The following is a description of a gene set: species: Mus musculus from publication Brown AL, Wilkinson CR, Waterman SR, Kok CH, Salerno DG, Diakiw SM, Reynolds B, Scott HS, Tsykin A, Glonek GF, Goodall GJ, Solomon PJ, Gonda TJ, D'Andrea RJ (PMID 16769770) Genes defining proliferation and self renewal potential of the bipotential myeloid cell line FDB. Mouse Gene Set: BROWN_MYELOID_CELL_DEVELOPMENT_DN Mechanisms controlling the balance between proliferation and self-renewal versus growth suppression and differentiation during normal and leukemic myelopoiesis are not understood. We have used the bi-potent FDB1 myeloid cell line model, which is responsive to myelopoietic cytokines and activated mutants of the granulocyte macrophage-colony stimulating factor (GM-CSF) receptor, having differential signaling and leukemogenic activity. This model is suited to large-scale gene-profiling, and we have used a factorial time-course design to generate a substantial and powerful data set. Linear modeling was used to identify gene-expression changes associated with continued proliferation, differentiation, or leukemic receptor signaling. We focused on the changing transcription factor profile, defined a set of novel genes with potential to regulate myeloid growth and differentiation, and demonstrated that the FDB1 cell line model is responsive to forced expression of oncogenes identified in this study. We also identified gene-expression changes associated specifically with the leukemic GM-CSF receptor mutant, V449E. Signaling from this receptor mutant down-regulates CCAAT/enhancer-binding protein alpha (C/EBPalpha) target genes and generates changes characteristic of a specific acute myeloid leukemia signature, defined previously by gene-expression profiling and associated with C/EBPalpha mutations., and this is the list of marker genes: Eif4e, Rcl1, Tespa1, 4930555B11Rik, Ppp1r14bl, Nop56, Sod1 (NCBI Gene Id 319325), Osbpl3, Ppef2, Rgs5, Paxbp1, Mfng, Tnfsf11, Ankrd10, Nutf2, Polr1b, Calr, Akr1c13 (aldo-keto reductase family 1, member C13), F2rl3, Nars1, Pgrmc1, Apex1 (apurinic/apyrimidinic endonuclease 1), Nme1, Dis3, Tmem97 (transmembrane protein 97), Msh2, Spint2, Gtpbp4, Ahcy, Tmtc2, Septin1, Slc22a3, Adgrg1, Shmt2, Gas5, Igkv4-77 (immunoglobulin kappa variable 4-77), Papss2, Hsph1, Cd48, Ivns1abp, Mboat2 (membrane bound O-acyltransferase domain containing 2), Rab27b, Cct6a, Akr1c12, Npl, Mgat5, Utp4, Cpa3, Slc16a1, Rif1, Trim28, Zfas1, H2-Aa, Gart, Stc2, Fcer1a, Mcpt8, Wdr43, Bin1, Fkbp4, Ripor1, Xpot, Csgalnact2, Rpl23, Aasdhppt, Cdk4, Nt5c3, Pcx, Sox4, Ikzf4, Nolc1, Odc1, Rcor2, Txk, Trim37, H2-Eb1, Timm8a1, Cdh17, Cbfa2t3, Ruvbl2, Slc7a5, Ctla2a, Tasp1, Sf3b3, Pdia5, Parp8, Erh, Hmgn1 (NCBI Gene Id 15312), Fbxw4, Hspd1, Serpina3g, F9, Fut8, Nsun2, Bzw2 (basic leucine zipper and W2 domains 2), Epb41l4aos, Tyms-ps, Kcnk5, F2r, Aqp9, Emx2, Sinhcaf, Mat1a, C1qbp, Trf, Ssr3, Ppan, Ptpn9, Lama5, Nop58, Fam20a, St7, Slc1a5, Mep1b, Slc7a8, Nt5c3b, Ikzf2, St6gal1 (beta galactoside alpha 2,6 sialyltransferase 1), Sytl3, Ide, Snhg5, Npm1, Nrip1, Srsf7, Nop16, Ifitm3, Smarcc1, 4930535E02Rik, Ncl, P2ry10 (purinergic receptor P2Y, G-protein coupled 10), Clec10a, H2-Ea, Epcip, Gnal, Psat1, Fut7, Nrgn, Gata2, Spns2, Cyp11a1, Trbv13-2